Given this list of marker genes S100A6, NOP58, PSMD2, EDARADD, TRMT12, CEMIP2, RFK, LTA4H, NOTCH1, NLRC3, BUD23, FKBP7, BAG1, FOXJ3 (NCBI Gene Id 22887), PIGO, ZEB2, TRPM4, PPM1L, ZC3H13, MMD, MGAT4A, BCL2L13, OXCT1, FIBCD1 (NCBI Gene Id 84929), ABITRAM, WBP1L (NCBI Gene Id 54909), KLF15, UBL3 (ubiquitin like 3), FANCA, SEC61A2, HAL, MARCO, ST3GAL6, SCAF4, MCCC2, DICER1, NEMF, GPR149, C15orf61, MTRFR, KCTD6, TAF5, DSTN, ATP5MK, ANKIB1, NUCB2, DPP4, HEXD, SLC49A4, STAG1, ATP5PF, MAP4K3, CDK8, WDR37, ARL5A, FAM98B, RFXAP, NSMCE2, PTHLH, CCT2, MATK, PTPRE, H3C14, PLA2G12A, NFATC1, CDH1, UBE4B, OSGIN2, ACTL6A, SON, EFCAB9, RAB3GAP2, TEKT5, CHKA, ERLIN1, CIR1, CAPN2, RRP15, GLRX, SYMPK, RAB3IP, SNX4, UPB1, ZUP1, MRPL3, TTLL3, IDE, TP53, PIK3CA, TNRC6C, CPA2, NRIP1, SFPQ, FMR1, TUT7, LAMA2, CSGALNACT2, PTGES2, MFSD8, TERT, GTF2H1, SPAG5, RAD54L, ST14, NCBP2AS2, TMCC3, ATF7IP, FRRS1 (ferric chelate reductase 1), MAMDC4, ATP5F1A, PUM2, RCL1, MTLN, SYNPO2L, ATP1B3, NELFE, RNF26, DOCK3, ST7, ACAD8, TRIM11, RBMXL1, PI4K2B, CHMP4B, CRYBG3, ABCD3, ZNF503, TAF7, STAC2, GPAT3, AUH (NCBI Gene Id 549), GARS1, GNA14, WIPF2, RABGAP1, DCLK3, PDSS1 (NCBI Gene Id 23590), LRATD2, SCML2, TEX9, PRDM15, SENP6, MTMR14, ROCK2, CCSER2, PRKAG2, LRRN1, PDS5A, DCTD, HACD2, PEPD, MYO7A, CCDC159, NIPSNAP1, WASHC3, EIF3A, TIMM29, MAF1, IPO8, ATAD3A, MEF2C, GEMIN8, FAM83E, SSPN, CSAD, PRICKLE3, SRRM2, RRP1B, SLC25A18, SLC25A23, HBG2, TUBA8, GLG1, ANKRD33B, BRIX1, CLPP, DNMT3A, TCF20, LMLN, SLC25A3, MFHAS1, XIST (X inactive specific transcript), LPIN2, ATP1B1, LRRC47, HMG20B, MTPAP, PIGQ, HEATR1, SAFB, POLB, DDX50, TSSK2, MED31, SYNJ1, CEP70, MTUS1, CD9 (NCBI Gene Id 928), RBM27, SEC63, here is a description of the gene set: Genes down-regulated in T reg: FOX3P knockout versus wildtype. Human Gene Set: GSE6681_DELETED_FOXP3_VS_WT_TREG_DN studied in species Homo sapiens from publication Williams LM, Rudensky AY (PMID 17220892) Analysis of Foxp3 ablated peripheral regulatory T cells. Regulatory T cells require the expression of the transcription factor Foxp3 for thymic development. It is not known whether continuous expression of Foxp3 is required for the maintained function of mature regulatory T cells in the periphery. Results indicate changes to the regulatory T cell developmental program in the absence of Foxp3.